Given this list of marker genes Chi3l1, Nagk, Mgat1, Chil6, Gnpda1, Ctbs, Aldh1a1, Aldh1a7, Chia1, Chil4, Amdhd2, Chit1, Renbp, Gnpda2, Chil5, Ovgp1, Chil3, Npl, here is a description of the gene set: Mouse Gene Set: GOBP_AMINO_SUGAR_CATABOLIC_PROCESS studied in species Mus musculus The chemical reactions and pathways resulting in the breakdown of any amino sugar, sugars containing an amino group in place of a hydroxyl group.